Given this list of marker genes RAD50, FAM162A, IL10RB, BLMH, NAGLU, UNC119B, ACAD9, PDS5B, ACBD6, POLB, HOPX, EMC8, XCL1, TNFAIP8L1, UNC119, MCOLN2, NDFIP2, PCLAF, CRCP, STMN1, TRAK1, PREP, GLRX, COMT, ELOF1, SLC37A4, PTGR1, IFI30, NDUFS5, POMP, MLLT3, TUBG1, PGLYRP1, UGDH, ARL14EP, TRIM37, TAF11, AHNAK, MNS1, GALK1, NSMAF, PDIA4, RNASEH2B, OAZ2, PMM1, KGD4, BRCA1, KIF4A, RBL1, CDC20, ELMOD3, KLRK1, ADSS1, LGALS3, NCBP2, DNMT1, DDIT4, CMPK2 (cytidine/uridine monophosphate kinase 2), DDX52, MT2A, HMBS, LXN, CNPY2, MRPL18, CKAP2, CYP51A1, TSPAN31, SMPD1, RPN1, AURKA, FDPS, TOP2A, HDHD2, BIRC5, SH3BGRL, SKAP2 (NCBI Gene Id 8935), HPF1, RFC2, TIMM9, RACGAP1, S100A6, CD200, SQLE, MKI67, CKAP5, DHCR7, IL18R1, TRIM41, GMNN, PAFAH1B3, IDI1, RC3H2, CDK1, PLEKHB2, RFC4, RBM10, RPA3, MAD2L1, HASPIN, FDFT1, HCFC1R1, CCR5, ACOT7, YBX3, CYTH3, CHCHD10, TMPO, SIVA1 (SIVA1 apoptosis inducing factor), DTD2, ZDHHC16, DECR1, F2RL1, PGAM1, CKS1B, YY1, TACC3, DCAF12, MGST3 (NCBI Gene Id 9272), LMNB1, NDUFS6, HK2, RCN2, MSMO1, NOCT, KIF23, TGDS, TTC33, PCYT2, CCDC6, ANLN, MRPS22 (mitochondrial ribosomal protein S22), POLR3K, TPI1, PLP2, METTL26, CCNB2, HLA-DOA, NVL, EZH2 (enhancer of zeste 2 polycomb repressive complex 2 subunit), PRKACA, LCLAT1, MEST, NCAPH, MTERF2 (NCBI Gene Id 80298), BCL2A1, DCK, GZMB (NCBI Gene Id 3002), CDKN2AIPNL, SAAL1, PDZD11, HMGCR, IL3RA, MFN1, NUSAP1, TMEM97, RIDA, HTATIP2, EBP, FKBP2, AK3, CISD1, CENPK, CRTAP, TXNDC12, NBN, CTLA4, RNF14, LUC7L3, CD79B, TMEM229B, SNRNP25, H2AB2, RNH1, FBXO6, CYB5B, ECPAS, RIOX2, HSDL2, XDH, BUB1, RFC5, CAPG, PSMD12, GTF2H4, ANXA2, TNFRSF9, HIP1R, RBPJ, RSPH3, IL16, PLK4, IFT27, PDCD2, CSNK2A2, CENPA, ACOT8, TAMM41, PRIM2, LGALS1, DESI1, here is a description of the gene set: Human Gene Set: GSE15930_NAIVE_VS_72H_IN_VITRO_STIM_CD8_TCELL_DN from publication Agarwal P, Raghavan A, Nandiwada SL, Curtsinger JM, Bohjanen PR, Mueller DL, Mescher MF (PMID 19592655) Genes down-regulated in comparison of CD8 T cells at 0 h versus those at 72 h. studied in species Homo sapiens Differentiation of naive CD8 T cells into cytotoxic effector cells requires three distinct signals- antigen (signal 1), costimulation -B7-1 (signal 2) and cytokine, either interleukin-12 or interferon-a/b (signal 3). Interaction of naive CD8 T cells with antigen and B7-1 programs cell division and proliferation whereas the presence of cytokines- IL-12 or IFNa/b promote survival, differentiation and memory establishment. In the absence of signal 3, the cells interacting with antigen/B7-1 undergo tolerance induction. The objective of this study was to elucidate the mechanisms how the provision of signal 3 promotes differentiation and averts tolerance induction in CD8 T cells. Trichostatin A is a pharmacological agent that inhibits histone deacetylase activity, hence regulating chromatin structure and gene expression and differentiation in many cell types. Gene signature profiles of IL-12, IFNa/b and trichostatin A stimulated cells were compared to elucidate the molecular mechanisms of gene regulation. Oligonucleotide microarray analysis is carried out to determine the extent and molecular nature of the CD8 T cell differentiation program induced by IL-12 or IFNa/b in concert with antigen and B7-1 signal.